Given this list of marker genes ITGA2, CHUK, BGLAP, RPS6KB1, PIK3R1, MAPK3, IL6ST, IBSP, TGFB1, SOCS3, IL11RA, IL11, CREB1, RUNX2, FYN, FES, IKBKB, RPS6, JAK2 (NCBI Gene Id 3717), RPS6KA1, PDPK1, HRAS, RAF1, PTPA, PIAS1, JAK1, MAPK1, GRB2, STAT1, PIK3R2, MAP2K1, ICAM1, YES1, BIRC5, TYK2 (tyrosine kinase 2), PIAS3, RELA, MAP2K2, STAT3, ATF1, SRC, PTPN11, BCL2, AKT1, here is a description of the gene set: IL11 signaling species: Homo sapiens Human Gene Set: WP_IL11_SIGNALING